The following is a description of a gene set: Genes down-regulated in STAT5 double knock-in T cells: control versus IL2 stimulation for 2h. studied in species Homo sapiens from publication Lin JX, Li P, Liu D, Jin HT, He J, Ata Ur Rasheed M, Rochman Y, Wang L, Cui K, Liu C, Kelsall BL, Ahmed R, Leonard WJ (PMID 22520852) Human Gene Set: GSE36888_UNTREATED_VS_IL2_TREATED_STAT5_AB_KNOCKIN_TCELL_2H_DN Cytokine-activated STAT proteins dimerize and bind to high-affinity motifs, and N-terminal domain-mediated oligomerization of dimers allows tetramer formation and binding to low-affinity tandem motifs, but the functions of dimers versus tetramers are unknown. We generated Stat5a and Stat5b double knock-in (DKI) N-domain mutant mice that form dimers but not tetramers, identified cytokine-regulated genes whose expression required STAT5 tetramers, and defined consensus motifs for dimers versus tetramers. Whereas Stat5- deficient mice exhibited perinatal lethality, DKI mice were viable, indicating that STAT5 dimers were sufficient for survival. Nevertheless, STAT5 DKI mice had fewer CD4+CD25+ T cells, NK cells, and CD8+ T cells, with impaired cytokine-induced proliferation and homeostatic proliferation of CD8+ T cells. DKI CD8+ T cell proliferation following viral infection was diminished and DKI Treg cells did not efficiently control colitis. Thus, tetramerization of STAT5 is dispensable for survival but is critical for cytokine responses and normal immune function., and this is the list of marker genes: FHL1, RBPJ, TRIB2, TERF2, UGCG, IGKV3-20, ABCA2, C19orf33, ABI3, AK3, UST, CEP68, SPIN1, THEM4, EVL, RHOF, GRIP1, NARS2, ELAVL4, EFHC1, CAND1, PCLAF, LTC4S, ASB2, TSPAN33, NCK2, ETS1, UTP20, ST18, BCL7A, CHAC2, CENPK, ZNF571, CREB5, ZNF251, BACH2, LBH, WDR54, LIMCH1, TGDS, CD1E, SDS, EIF3K, TCF3, MAP4K1, DGKE, TRAF5 (NCBI Gene Id 7188), PABPC1L, ZWINT, SP140L, H2AC11, SMPD3, CD160, CCDC34, PON2, H2AC25, SNHG12, PUM3, CD38, ZSCAN5A, SIGLEC17P, SPIB, GART, NAV1, AXL, LINC01126, STIL, RAVER2, PEBP1, GINS1, TESPA1, RPLP2, PACC1, MMD (monocyte to macrophage differentiation associated), H2BC13, GNG7, TRAF4, PLA2G6, PPP2R1B, TFDP2, NDUFAF4, MAT2A, TMEM182, SUSD3, ATAD1, UTP6, FADS2, TRAP1, SMAGP, SLAMF7, PRSS23, SPRY2, UPF2, TINAGL1, UBE2N, PTTG1, HAPLN3, ZNF284, KLRF1, RPS11, ZAP70, CTTNBP2NL (NCBI Gene Id 55917), CSTPP1, ACTR3, CDCA7L, MAP3K21, RAN, ATP1B1, MTFMT, RABEP2, NDC80, DHX35, MRC2, IL18RAP, RPAP2, ODF2L, REC8, ARHGAP15, GAS6, PRDX2, ARL4C, PPM1J, CYP2S1, CCNG1, CCL5, SOX12, MBD5, SLC9A7, IL2RB, DENND1B, MRC1, ARMCX2, ASAH2B, ZCRB1, S1PR5, PNMT, A2M, IFT80, RPS18, UHRF1, ARHGAP5, C19orf44, ARL2, RALA, PRC1, EEF1E1, SLC46A1, ADAM28, HLTF, ZBTB5, SP140, ENPP3, FCN3, NIT2, MTERF2, IL7R, DENND2B, HLA-DPB2, DDX47, ZCCHC8, RASGRP1, TAMALIN, ADA (adenosine deaminase), OVGP1 (NCBI Gene Id 8684), GRAMD2B, RBM28, TOP1MT, EFCAB5, ITK, SIT1, HIVEP2, TPD52, RUVBL1, P2RY6, BCAR3, UQCC1, ITGB7, ACER3, HYLS1, ACAP1, UNC13B, ABCE1, PPP1R16A, STAT4, FCMR, ZNF789, HEATR5B, DNAJA4, NAA40, ACOT7, CLIC2, NOL11, PLA2G12A, PACS2, CEP128, TCEA3